Given this list of marker genes UNC80, CTSK, KDM6A, PCGF2, SIN3A, ACBD6 (acyl-CoA binding domain containing 6), PIGN, CNOT3, WDR26, MIR140, POC1A (NCBI Gene Id 25886), NDN, CRELD1, SNRPN, AHDC1, TCF4, HERC2, TELO2, FBN1, SATB2, FBXO11, SMC1A, CDKL5 (cyclin dependent kinase like 5), CTNND2 (catenin delta 2), DVL1, USP7, CHUK, EIF4A2, MAGEL2, DPM1 (NCBI Gene Id 8813), SEMA5A, KMT2A, KMT2D, CENPE, GALNT2, COL11A1, MEG3, NGLY1, NPAP1, DPH1, TAF6, CSGALNACT1, NALCN, PPM1D, BPTF, HPGD, FGFR2, SIM1, MKRN3, MAPK8IP3, KIF5C, SATB1, NTNG1, PRIM1, WNT5A, SPECC1L, HUWE1, MCTP2, COG4, SMC3, ALG13, SON, EVC, SLC35C1, MTFMT, KCNJ5, AFF4, KIFBP, FAM50A, CCBE1, CACNA2D1, NIPBL, IGF1R, TRPV4, RTL1, CANT1, CDK10, ROR2, CHD6, LTBP3, FMR1, NSUN2, COL3A1, DPH2, FGD1 (FYVE, RhoGEF and PH domain containing 1), CUL4B, HTT (NCBI Gene Id 3064), SNORD115-1, RNF2, GJA1, GABBR2, ADNP (NCBI Gene Id 256440), HDAC8, FBXO28, RAD21, IGF2, PWRN1, OCA2, CTCF, PWAR1, WRN, MECP2, LAS1L, SLCO2A1, SNORD116-1, HDAC4, BRD4, TBCE, USP9X, XYLT1, KCNJ2, DLK1, ORC1, TUBB3, WDR81, EVC2, SMARCD1, LIG4, PUM1, SLC6A17, COG1, RMRP, RECQL4, here is a description of the gene set: Small hand Human Gene Set: HP_SMALL_HAND studied in species Homo sapiens Disproportionately small hand.